The following is a description of a gene set: species: Homo sapiens The live vaccine strain (LVS) of Francisella tularensis is the only vaccine against tularemia available for humans, yet its mechanism of protection remains unclear. We probed human immunological responses to LVS vaccination with transcriptome analysis using PBMC samples from volunteers at time points pre- and post-vaccination. Gene modulation was highly uniform across all time points, implying commonality of vaccine responses. Principal components analysis revealed three highly distinct principal groupings: pre-vaccination (-144 h), early (+18 and +48 h), and late post-vaccination (+192 and +336 h). The most significant changes in gene expression occurred at early post-vaccination time points (<=48h), specifically in the induction of pro-inflammatory and innate immunity-related genes. Evidence supporting modulation of innate effector function, specifically antigen processing and presentation by dendritic cells, was especially apparent. Our data indicate that the LVS strain of F. tularensis invokes a strong early response upon vaccination. This pattern of gene regulation may provide insightful information regarding both vaccine efficacy and immunopathogenesis that may provide insight into infection with virulent strains of F. tularensis. Additionally, we obtained valuable information that should prove useful in evaluation of vaccine lots as well as efficacy testing of new anti-F. tularensis vaccines. Human Gene Set: FULLER_PBMC_F_TULARENSIS_VACCINE_LVS_AGE_22_54YO_18HR_TO_48HR_EARLY_DN from publication Fuller CL, Brittingham KC, Porter MW, Hepburn MJ, Petitt PL, Pittman PR, Bavari S (PMID 17349694) Genes down-regulated in peripheral blood mononuclear cell (18 to 48)h vs 0h in adults (22-54) after exposure to F. tularensis vaccine LVS, time point 18 to 48H. Comment: Pattern 4, down early. These 21 of genes in pattern linked to immune-related functions., and this is the list of marker genes: TRAF1, PPP2R5C, PTPRCAP, CD28, CD3E, NOSIP, UBE3A, STAT3, RHOH, FASLG, PRKCH, STMN3, NACA, NKG7, CD96, TNFRSF25, CD40, NAP1L1, NUMA1, IFNA10, CD37, KLRK1, F2R, GSPT1, TRBV19, KLF2, IFNA17 (NCBI Gene Id 3451), NKTR, TRAF5, TNF, ZAP70, KLRC3, CCL5, EIF3M, F11R, CD3G, RORA (RAR related orphan receptor A), CD3D